The following is a description of a gene set: Human Gene Set: GSE14415_ACT_VS_CTRL_NATURAL_TREG_DN from publication Haribhai D, Lin W, Edwards B, Ziegelbauer J, Salzman NH, Carlson MR, Li SH, Simpson PM, Chatila TA, Williams CB (PMID 19265124) The gene expression profile of peripheral Foxp3+ natural regulatory T cells isolated from Foxp3/EGFP bicistronic mice was compared to that of in vitro-induced regulatory T cells and to CD4+ conventional (Foxp3-) T cells. The role of the regulatory T cell transcription factor Foxp3 in shaping the transcriptosomes of natural and induced regulatory T cells was analyzed using mice expressing a mutant FOXP3-EGFP fusion protein (Foxp3deltaEGFP). We used gene expression microarrays to examine the transcriptional programs of natural and induced regulatory T cells and the function of Foxp3 in organizing the transcriptosomes of the respective cell type species: Homo sapiens Genes down-regulated in natural T reg: activated versus naïve., and this is the list of marker genes: KCNJ8, TSPYL2, AKT3, NR1D2, BAG5, SOCS6, MTAP, RNF141, NEURL3, ZBTB20, IRF7, POLR1C, CHCHD6, ZNF708 (zinc finger protein 708), DZIP1, CBR1, ARRDC3, XRCC5, GNL1, TRMT112, RPL30, IARS1, ZNHIT6, VPS28, QTRT1 (NCBI Gene Id 81890, queuine tRNA-ribosyltransferase catalytic subunit 1), PRPF6, PALS1, NFU1, GSTK1, MAML2, GNG5, CARD6, BBS2, FAM162A, MFSD6, PRSS12, RPAP3, ZEB1, ACTR8, FAM120B, MDC1, XCL1, TRIM39, TMCC1, POLR2E, MRPS28, HEATR1, DUSP1, GPATCH4, HPCAL1, F2RL1, SMYD3, RAB6B, KIZ, TRIM13, ARHGAP35, PIGY, SLC49A4, NR4A1, PARP16, TNFSF8, RUNDC3B, RPP40, NFIL3, BAMBI, RAB23, RFX3, ZFP62, MDN1, VKORC1, CUX1, EVL, LAT, ASCC1, MICU3, KHK, GSTA4, TXNDC15, SLC25A36, NDUFAF4, MAP4K5, KLHDC2, GNPTG, CLYBL, PARP6, ARL6IP6, SSH2, MSANTD2, SMPDL3A, SLC4A1AP, GPR183, RHOB, CDC37L1, MESD, FBL, EPHX1, TCTA, TAF4B, IL7R, TCEAL1, THEM4, EBAG9, SLC12A2, CD72, UTP25, BCOR, NFE2L2, WDR75, BTG2, HSD17B11, FCHSD2, RRP15, CD55, NHLRC3, CXCR4, GUK1, KLRK1, POLR1H, CD7, RPL19, MRTO4, NOP14, KBTBD11, SIDT1, HINT2, EXOSC10, PLEKHA1, HSD17B8, FOXO1, DNAJC17, EIF3F, DPH6, RPL36A, PTTG1, POLB, TRNAU1AP, NT5E, RPTOR, GPR155, TANGO6, TTBK2, DPH5, DDHD2, NOP10, FOXP1, FOCAD, TCF7, WDR74, CD101, PCCA, NDUFS7, CD28, DGUOK (NCBI Gene Id 1716), MCOLN1, EEF1D, NBN, IL15, RMDN1, PARP8, NSMCE1, USE1, SPACA1, INSR, BOLA2, TMEM42, SAMD3, CCND2, DMRTA1